The following is a description of a gene set: from publication Chen Y, Wang X (PMID 31504780) Genes predicted to be targets of miRBase v22 microRNA hsa-miR-7975 in miRDB v6.0 with MirTarget v4 prediction scores > 80 (high confidence targets). Human Gene Set: MIR7975 studied in species Homo sapiens, and this is the list of marker genes: DNAJC16 (DnaJ heat shock protein family (Hsp40) member C16), ATP2C1 (ATPase secretory pathway Ca2+ transporting 1), APEX1, PTN, ATP6V1A, PCDH19, VPS53, STX2, UBR3, ACVR1, INTS6, OAZ3, MAPK9, C1orf74, GINS3, PPIL4, CCNE2, SHANK2, LAMC1, SMG1, HAPSTR1, SPOPL, NCAM1, PSENEN (presenilin enhancer, gamma-secretase subunit), R3HDM1, ANKRD42, CARNMT1, CERT1, MPP2, ABCG1, SLC35F1, ASXL2, MACIR, BAG5, PPM1M, DYNLL2, PRR16, TMEM183A, ATG10 (autophagy related 10), TSR1, PRKACB, PDE5A (phosphodiesterase 5A), STRN3